Given this list of marker genes Htr4, Cc2d1a, Rhog (NCBI Gene Id 72751), Neurl1a, Iqgap1 (IQ motif containing GTPase activating protein 1), Ptpn1, Asic2, Dock4, Psd (NCBI Gene Id 73728), Rac3, Dock1, Nrxn2, Gna13, Map1b, Arhgef15, Ppp1r9b, Nectin3, Arhgap33, Usp9x, Fam107a, Cyfip2, Rtn4, Cpeb3, Srgap3, Carmil3, Afdn, Mark1, Slc12a5, Nckipsd, Sema4c, Flrt2, Pum2, Trim47, Nae1 (NCBI Gene Id 260355), Numb, Rac1, Numbl, Dock10, Zdhhc8, Vps35, S1pr2, Lzts3, Ube3b, Dcx, Asic1, Nedd8, Rtn4r, Crmp1, Syndig1, Elmo1, Dclk1, Ube2m, Lzts1, Lrp4, Sigmar1 (NCBI Gene Id 18391), here is a description of the gene set: Mouse Gene Set: GOBP_REGULATION_OF_POSTSYNAPSE_ASSEMBLY Any process that modulates the frequency, rate or extent of postsynapse assembly, the aggregation, arrangement and bonding together of a set of components to form a postsynapse. species: Mus musculus